Given this list of marker genes E2F1, BBC3, PPP1R13B, TP63, TP73, TFDP1, TP53BP2, TP53, TFDP2, here is a description of the gene set: Reactome Pathway: Activation of PUMA and translocation to mitochondria part of: Activation of BH3-only proteins species: Homo sapiens Puma is transactivated in a p53-dependent manner and by E2F1. Activated Puma is translocated to mitochondria.